The following is a description of a gene set: from publication Chen Y, Wang X (PMID 31504780) Mouse Gene Set: MIR_202_5P species: Mus musculus Genes predicted to be targets of miRBase v22 microRNA mmu_miR_202_5p in miRDB v6.0 with MirTarget v4 prediction scores > 80 (high confidence targets)., and this is the list of marker genes: Rnf182, Prrx1, Cstdc2, Zfp532, Piwil1, Zpbp, Golim4, Cuedc1, Aak1, Phldb2, Sinhcaf, Cckbr, Spag11b, Cd28, Myrf, Naa15, C1ql3, Sorcs1, Fbxo45, Ttc13, Ythdf2, Pmp22, Plekha1, Pdgfd, Add2, Slc9a6, Rbfox2, Kmt2a, Hes5, Fam76a (family with sequence similarity 76, member A), Plagl2, Agbl2, Ntrk3, Robo2, Shox2, Slitrk4, Yipf5, Rbm18, Arxes1, Vwde, Pdha1, Tango2, Mysm1, Tyw5, Bicd2, Pgap1, Tmtc4, Nus1, Naa20, Dnmt3l, Elk4, Vti1b, Scly, Tet1, Tbc1d24, Parva, Esyt3, Echdc1, Grin2c, Tardbp, Bicd1, Klk9, Cnot2, Pdp1, Oard1, Ppm1d, Lbr, Zfhx4, Pcgf2, Lpgat1, Entpd4, Tomm20, Bcl2, Fmnl2, Porcn, Rock1, Ranbp17, Tmem100 (NCBI Gene Id 67888), Nr2f2, Rbm41, Jun, Hsf2, Erbin, Vangl2, Tia1, Gem, Pan3, Zfp60, Usp15